Given this list of marker genes APLP1 (NCBI Gene Id 333), MRAP2, PDE3B, PDE4B, GNAI2, MGRN1, CRTC3, MRAP, PDE3A, PDE2A, ATP2B4, ARRDC3, PDE4D, here is a description of the gene set: species: Homo sapiens Any process that stops, prevents or reduces the frequency, rate or extent of an adenylate cyclase-activating G protein-coupled receptor signaling pathway. Human Gene Set: GOBP_NEGATIVE_REGULATION_OF_ADENYLATE_CYCLASE_ACTIVATING_G_PROTEIN_COUPLED_RECEPTOR_SIGNALING_PATHWAY